The following is a description of a gene set: Mouse Gene Set: GOBP_DOUBLE_STRAND_BREAK_REPAIR_VIA_SYNTHESIS_DEPENDENT_STRAND_ANNEALING SDSA is a major mechanism of double-strand break repair in mitosis which allows for the error-free repair of a double-strand break without the exchange of adjacent sequences. The broken DNA searches for and base pairs with a homologous region in an intact chromosome. DNA synthesis initiates from the 3' end of the invading DNA strand, using the intact chromosome as the template. Newly synthesized DNA is then displaced from the template and anneal with its complement on the other side of the double-strand break. species: Mus musculus, and this is the list of marker genes: Dmc1, Mcmdc2 (NCBI Gene Id 240697), Rad51, Rad51c, Helq, Rad52 (RAD52 homolog, DNA repair protein), Rad54l, Xrcc3, Fancm